Given this list of marker genes IL7R, TESPA1, ADAM8, EGR3, GLI2, RASGRP1, VNN1, SHH, IHH, ADA, IL2RG, here is a description of the gene set: Human Gene Set: GOBP_POSITIVE_REGULATION_OF_T_CELL_DIFFERENTIATION_IN_THYMUS studied in species Homo sapiens Any process that activates or increases the frequency, rate or extent of T cell differentiation in the thymus.